Given this list of marker genes GINM1, SPG21, ZMAT3, AKAP12, RGS16, AEBP1, PDZK1 (PDZ domain containing 1), LLCFC1, PPARGC1A, C12orf56, GLUD2, IRF4, ALYREF, MIR4290HG, LCP1, TCL6, ABCG2, HRG, IL37 (interleukin 37), MRPL44, NOC2L, ARHGEF28, SLC13A5, ARL4A, GABPB1-IT1, FRMD1, HS1BP3, TBATA, UBE2G1, ADGB, RAB40A, NCDN, BTBD3, TRANK1, PDGFRB (platelet derived growth factor receptor beta), BEX1, MSTN, CTSE, SYN1, UPK1B, LINC01711, PRR7-AS1, HCG22, MRPL20, TBC1D2, ELFN1, GNB1, RP1L1, HCFC2, F2RL3, GABPA, HRC, VAPA, TYMP, NEURL3, RNF217, GSN, ATXN7L2, LINC02297, ARF5 (ADP ribosylation factor 5), LINC02145 (long intergenic non-protein coding RNA 2145), PRIM2, EPPIN, HSPD1, CDK9 (NCBI Gene Id 1025), TMX1, NAGS, ATF4, ZFR2, GABRP, PDE1B, CEP192P1 (NCBI Gene Id 643201), ADAMTSL1, TPX2, FOXE3, PTPN6, BCL6B, TCF12-DT, ATP1A1, PKDCC, NBL1, TXNDC2, ARHGAP17, CRMP1 (NCBI Gene Id 1400), CD300C, CLSTN2, PDE4D, FAXDC2, CHAC1, LIFR-AS1, NXF2, LINC00052, SCGN, AQP1, KCNQ2, ZDBF2, ENSA, PPIC, LRRC38, GAB3, MAP3K20-AS1, HTRA3, CFAP74, MUC3A, HCG18, SPIB, TNKS2, LINC01102, ITGB4, IDH2, TECTA, MYB, UHRF1 (NCBI Gene Id 96185), PICALM, AIFM1, GRK4, ENPP6, PRKAR1B (protein kinase cAMP-dependent type I regulatory subunit beta), TM4SF18, NR2C2AP, CD163, FBXL14, SHOX2, DNAJC18, PDX1, FAM124B, TRAFD1, PRICKLE3, METTL21EP, BRWD1-AS1, PTGES, PPP1R26, UBA5, HRK, FOXA1, MAP2K7, ACTB, RNASE3, ZNF30, SRPRB, SPATC1, PDIA3, CABP4, CYP2J2, PPP1R2, STK4-DT, IGKV3-20, TAS2R38, FSD1, PDGFB, SRGAP3, NATD1, PIEZO2, CKM, KCTD12, ACKR1, INKA1, PTGFR, OTUB2, MKI67, RHO, IGF2R, ZNF740, PMVK, PRR15, PKD1L1, CACNB4, SH3BP1, GLT1D1, SLC15A1, SMR3B, KCNV2, NDRG2, FLNC, CYB561A3, SLIT2, LCNL1, MCL1 (NCBI Gene Id 4170), GPHA2, LINC00589, MAPDA, MORN3, FHOD1, COPZ2, HOTAIR, PCDHB7, here is a description of the gene set: Tumor growth is associated with a profound alteration of myelopoiesis, leading to recruitment of immunosuppressive cells known as myeloid-derived suppressor cells (MDSCs). Analyzing the cytokines affecting myelo-monocytic differentiation produced by various experimental tumors, we found that GM-CSF, G-CSF, and IL-6 allowed a rapid generation of MDSCs from precursors present in mouse and human bone marrow (BM). BM-MDSCs induced by GM-CSF+IL-6 possessed the highest tolerogenic activity, as revealed by the ability to impair the priming of IFN- -producing CD8+ T cells upon in vivo adoptive transfer. Moreover, adoptive transfer of syngeneic, GM-CSF+IL-6-conditioned MDSCs to diabetic mice transplanted with allogeneic pancreatic islets resulted in long term acceptance of the allograft and correction of the diabetic status. Cytokines inducing MDSCs acted on a common molecular pathway. Immunoregulatory activity of both tumor-induced and BM-derived MDSCs was entirely dependent on C/EBP transcription factor, a key component of the emergency myelopoiesis triggered by stress and inflammation. Adoptive transfer of tumor antigen-specific CD8+ T lymphocytes resulted in therapy of established tumors only in mice lacking C/EBP in myeloid compartment. These data unveil another link between inflammation and cancer and identify a novel molecular target to control tumor-induced immune suppression. We used gene expression analysis to identify those factors, secreted by tumor-infiltrating MDSC, which could drive emathopoiesis. Moreover we compare gene expression profile of tumor-induced MDSC, obtained from either the spleen and the tumor infiltrate of tumor bearing mice, and in vitro bone marrow-derived MDSC. Genes up-regulated in CD11b EL4 Tumor from C57BL6 mouse versus CD11b MCA203 Tumor from C57BL6 mouse. from publication Marigo I, Bosio E, Solito S, Mesa C, Fernandez A, Dolcetti L, Ugel S, Sonda N, Bicciato S, Falisi E, Calabrese F, Basso G, Zanovello P, Cozzi E, Mandruzzato S, Bronte V (PMID 20605485) studied in species Homo sapiens Human Gene Set: GSE21927_EL4_VS_MCA203_TUMOR_MONOCYTES_UP